The following is a description of a gene set: Mouse Gene Set: GOBP_ENDOCARDIAL_CUSHION_TO_MESENCHYMAL_TRANSITION A transition where an endocardial cushion cell loses apical/basolateral polarity, severs intercellular adhesive junctions, degrades basement membrane components and becomes a migratory mesenchymal cell. species: Mus musculus, and this is the list of marker genes: Has2, Hey1, Efna1, Hey2, Acvrl1, Twist1, Eng